Given this list of marker genes Hsph1, Hspa5, Hspa4, Hspa8, Tor1a, Hspd1, Cct3, Clpx, Trap1, Hspa1b, Cct6b, Cct7, Cct4, Hspa1a, Hspa2, Cct6a, Cct5, Hspa9, Hsp90ab1, Hspa14, Cct8, Hspa13, Hsp90b1, Hyou1, Cct2, Tcp1, Hspa1l, Hsp90aa1, Hspa4l, here is a description of the gene set: species: Mus musculus Binding to a protein or a protein-containing complex to assist the protein folding process, driven by ATP hydrolysis. Mouse Gene Set: GOMF_ATP_DEPENDENT_PROTEIN_FOLDING_CHAPERONE